Given this list of marker genes GPR45, UGDH, SEPTIN9, HS3ST1 (NCBI Gene Id 9957), GATD3, DNASE2, ECM1, MARCHF2, BMP2K, CRIP1, CABIN1, XRCC4, GZMH, PSMC3, RAB9A, PIP4K2A, PIR (NCBI Gene Id 8544), SPINT2, MPPE1, VPS52, FRMD4B, EXOSC9, MAN2C1, IFFO1, RBP1, URI1, PHYH, LAIR2, MDN1, VAT1, FBP1, NDUFB5 (NCBI Gene Id 96666), VPS39, TDRD3, HLA-DRB4 (NCBI Gene Id 3126), SCCPDH, ZBED1, CES1, MEF2A, ENTPD1, HNRNPDL, FNDC3A, CD2AP, SLC38A6, UBXN8, ACSM3, MPI (mannose phosphate isomerase), CD86, FOXK2, MRPS11, GPNMB, SLC23A2 (solute carrier family 23 member 2), TSPAN4, OSBPL2, NQO2, ACADM (NCBI Gene Id 51779), QKI, CSF3R, ADAR, NAGLU, GM2A, UBA7, SNX17, PDIA3, DGKZ, FAM53B, GALK1, IQGAP2, CIZ1, MYL6B, PTPN22, CTSL, IFI30, ST14, DNPH1, CAPN2, ANXA6, PDIA6, CTSD, CDKN1C, IQSEC1, DDHD2, HEXA, FGR, CFD, GGA2 (NCBI Gene Id 23062), NIPSNAP1, MGAT1, ST6GALNAC2, RNF10, CLN3, WWP1, ASAH1, TBC1D1, ACAT1, TFDP1, TARBP1, GALC, HADH, NUCB1, CBX6, RENBP, PLCL2, PDE3B, APOC1, GBA1, MPP1 (MAGUK p55 scaffold protein 1), VEGFB, UBE2D2, ZNF160, LAIR1, PON2, PTPRO, CRYZ, CD151, IRAG2, LGALS9, TAF4, GSDME, APOE, TNFSF12, THOC1, ATP2A3, FKBP15, KLHL18, PLOD3, CLEC10A, PLCB2, PTPA, SLC5A6, ASGR2, ACY1, SUPT6H, TIE1, GPC4, SHMT2, IFRD2, CD163, PMP22, SHB, PRKACB, ZNF32, ZWINT, DOK2, SELENOP, DAG1, GRN, CTSZ, MRPL28, SHMT1, ATM, BATF, ATP5MG, METTL13, MRC1, CEBPA, ALDH3A2, SREBF2, ACP5, ILVBL, FABP4, BCAS2, CD300A, FAM13A, SLCO2B1, MTMR4, SYNGR2, KLRB1, DHX38, BCL2L2, GRAMD4, HOMER3, ITGB5, TIMP2, TXNRD2, MAN2A2, DECR1, LHFPL2, FAM131B, FZD2, BLOC1S1, HDAC4, LY86, ZFYVE26 (NCBI Gene Id 338378), HSP90B1, TPST2, COX11, EI24, FN1, OSBPL1A (NCBI Gene Id 55097), PRPS1, PAFAH1B3, VPS35L, CDK4, IDI1, LIPA, GGCT (gamma-glutamylcyclotransferase), ARL2BP, MRPL19, NCF4, here is a description of the gene set: Genes down-regulated in the in vitro follicular dendritic cells from peripheral lymph nodes (96h): Pam2CSK4 versus tretinoin and Pam2CSK4. Human Gene Set: GSE19401_PAM2CSK4_VS_RETINOIC_ACID_AND_PAM2CSK4_STIM_FOLLICULAR_DC_DN studied in species Homo sapiens Germinal centers (GCs) are clusters of activated B cells built on stromal cells known as follicular dendritic cells (FDCs). In the Peyer’s patches (PPs), GCs are chronically induced by bacteria and are the major sites for generation of gut IgA immune responses. Whether FDCs directly contribute to the IgA production in PP GCs is unknown. To investigate the role FDCs in gut immune system, we examined comprehensive gene profiles of FDCs purified from PPs or perypheral lymph nodes (pLNs) with or without immunization. We also tried to reconstitute the PP FDC signature in vitro by pulsed or continuous stimulation of pLN FDCs through TLRs, RARs or simultaneously through TLRs and RARs. from publication Suzuki K, Maruya M, Kawamoto S, Sitnik K, Kitamura H, Agace WW, Fagarasan S (PMID 20643338)